The following is a description of a gene set: species: Mus musculus from publication Tabula Muris Consortium (PMID 32669714) Mouse Gene Set: TABULA_MURIS_SENIS_THYMUS_PROFESSIONAL_ANTIGEN_PRESENTING_CELL_AGEING, and this is the list of marker genes: Rpl36, Rpl13 (ribosomal protein L13), Gimap1, Fau (FAU ubiquitin like and ribosomal protein S30 fusion), Cd22, Cd79a (CD79A antigen (immunoglobulin-associated alpha)), Shisa5, Rps16, Rpsa, Ltb, Rplp2, Rpl36a, Rpl13a, Rps24, Eef1a1, Rps23, Mzb1, Tnrc6b, Cd79b, Rps10, Rps19, Rpl27a, Rpl21, Rps7, Rpl35a, Rpl11, Rps4x, Rpl37a, Kmt2e, Rpl9, Rpl35, Tpt1, Fus, Pou2af1, Rps20, Cd74, Rps8, Jchain, Jpt1, Rpl17, Rpl8, Glcci1, Rps13, Rpl23, Rpl38, Rps21, Rac2, Fcmr, Rbm39, Rps15a, Rpl18a, Rpl24, Cnp, Fubp1, Rpl7 (ribosomal protein L7), Rps27, Cd19, Coro1a, Nubp1, Ptprcap, Cd2, Gimap6, Rps3a1, Rpl6, Rps29, Ms4a1, Rpl12, Uba52, Rpl23a, Cd37, Tnfrsf13c (tumor necrosis factor receptor superfamily, member 13c), Gimap7, Rps15, Rpl5, Fcrl1, Rps3